Given this list of marker genes KMO, IDO2, HAAO, NADSYN1, AANAT, IL4I1, AFMID, ASMT, TDO2, ATP7A, IDO1, KYNU, ACMSD, GCDH, here is a description of the gene set: studied in species Homo sapiens The chemical reactions and pathways involving indolalkylamines, indole or indole derivatives containing a primary, secondary, or tertiary amine group. Human Gene Set: GOBP_INDOLALKYLAMINE_METABOLIC_PROCESS